Given this list of marker genes CRYBB2, COMP, FMOD, HTRA1, MMP12, PTGS1, CXCL8, DPT, TNFRSF11B, THBS2, MMP10, SERPINB2, COL15A1, CST6, here is a description of the gene set: from publication Ly DH, Lockhart DJ, Lerner RA, Schultz PG (PMID 10741968) Human Gene Set: LY_AGING_MIDDLE_UP Genes up-regulated in fibroblasts from middle-age individuals, compared to those from the young donors. studied in species Homo sapiens Messenger RNA levels were measured in actively dividing fibroblasts isolated from young, middle-age, and old-age humans and humans with progeria, a rare genetic disorder characterized by accelerated aging. Genes whose expression is associated with age-related phenotypes and diseases were identified. The data also suggest that an underlying mechanism of the aging process involves increasing errors in the mitotic machinery of dividing cells in the postreproductive stage of life. We propose that this dysfunction leads to chromosomal pathologies that result in misregulation of genes involved in the aging process.